Given this list of marker genes AGO4, ATG14, ERCC4, FRMD6, RAD51B, BRWD3, RAB12, SYT6, SBF2, LY75, RACGAP1, PAN3, PEX5L, BTBD3, PSD, NFIA, RTCA, FAT3, AKAP1, RBM25, ACVR1, ACSL1, WDFY3, RAPGEF4, HSPA8, HEG1, LCORL, DAAM1, BRWD1, TAFA1 (TAFA chemokine like family member 1), IGF1, AGO1, ST8SIA5, APCDD1, ZBTB20, ACSL4, NCKAP5, FOSL1, CHD5, FERMT2, BLCAP, CPEB1, PTP4A1, SPATA2, LRRTM2, SPOCK1, DPYSL2, LRP12, MET, TSC1, ZNF862, TFCP2L1, SIX4, USP33, PPARG, PHAF1, ACBD5, CCDC6, GTF2H1, SAR1B, VGLL4, KCNA4, CGGBP1, LGALSL, WDR20, TMOD1, MFSD6, CAPRIN2, SNX2, LPGAT1 (lysophosphatidylglycerol acyltransferase 1), NECTIN3, FBXO48, AAK1, RNF38, G0S2, SPHK2, MIER1, BHLHE41, PIK3CB, ARHGEF4, WDR47, ELK3, NPNT, BPTF, USP28, BTF3L4, MIGA2, MMGT1, OTUD3, LRIG1, JMY, TEX2, BTBD7, BMPR2, THOP1, ITGB8, SLC6A6, ZFYVE9 (NCBI Gene Id 9372), BTAF1, POU4F1, ABHD3, ULK2, ING2, HOXD1, DCBLD2, EPC2, VCF1, HECA, CEP170, RALGPS2, MBNL3, PIK3C2A, DIAPH3, POP7, EGLN3, SERBP1, LSMEM1, TLCD3A, SOX4, MECP2, ABRAXAS2, FBXO28, HIVEP2, LRRK2, PLAA, ZBTB18, RASD1, OSBPL6, G3BP2, TNRC6C, CD69, MYBL1, LONRF3, TBL1XR1, FIBIN, ITPRIPL2, INO80, UBA3, MIGA1, ZNF800, DENND10, TMEM50B, SEL1L3, LMLN, TOGARAM1, MID1IP1, PGM2L1, CCNY, SAMD8, FUT9, GJA1, MTMR10, AR, WEE1, SLC44A1, SPTY2D1, IRF1, PSAP, PHF12, BAHD1, DLL1, WNK1, KRTAP26-1, NHLH2 (nescient helix-loop-helix 2), AGFG1, MDFIC, CYP2U1, CIT, NACC2, CUL3, MAP3K20, HOXA3, PRKD3, THSD7A, JARID2, SULF1, GAREM1, WDR33, PIGA, DNAJC16, AKIRIN2, ABCB7 (NCBI Gene Id 8252), ACBD3, VPS13D, TRPC3, PIKFYVE, ROBO2, EREG, ITPR1, MSMO1, TMEM250, ANKIB1, PCNX1, BTG1, NSD3, HPRT1, HS3ST5, MPHOSPH9, ZBTB4, UBE3B, ARHGAP21, ZNF107, TANC2, SLAIN1, CSMD1, ABCC5, ARHGEF26, EPS15, SHANK2, PMEPA1, FASTK, RRAGD, DICER1 (NCBI Gene Id 4333), TET3, CENPO, BAG5, SYBU, GADD45A, NFIB, ASXL2, SMOC1, DENND4C, SZRD1, RTN1, STIM2, CRACD, ERBIN, CASD1, SNIP1, ARHGAP1, TENT2 (NCBI Gene Id 167153), ZNF217, AKAP11, LDLR, ATG16L1, RFX7, MAF, MACIR, DLG5, JADE1, FOXF2, FYN, CNOT6, SLMAP, KDM2A, CAMSAP2, PIP4P2, ATP6V1B2, MB21D2, CLCN5, UBE2D2, TRIM2, PRUNE2, UBB, CNOT4, CPEB3, PHACTR2, STON2, SCUBE3, TES, CFL2, RUNX3, DCUN1D3, FMR1, CBX6, ARAP2, DOCK3, RAI2, CHST1, CDK19, EMX2 (empty spiracles homeobox 2), PRKAA1, NPAT, PHF20, MAP3K12, PPP6R2, SERINC3, DNAL1, LDAF1, RBBP8, ZNF594, MTCL1, CYSLTR1, KMT2C, CBLB, ZNF609, DSEL, ARL6IP1, RNF145, DGKE, IL1RAP, RPS6KA5, CBFB, RNF216, LRP8, PTPRG, ZMAT3, ARHGAP12, FZD6, MEMO1 (NCBI Gene Id 63983), BMP3, PLCB1, DYNLL2, MDM4, HCFC2, RO60, SLC2A4RG (SLC2A4 regulator), STX6, ESR1, PHF14, SOCS5, MBD2, NRBF2, IMPDH1, RAB30, PDZD11, ERP44, CDS1, KIAA1191, UBXN2B, C2orf15, RAB5A, CLIP1, SH3D19, SALL3, CCDC126, DCAF8, SPEN, PTPN4, KBTBD8, TSHZ1, EDN1, DDX6, SRSF2, SNX31, VPS37A, PPP1R15B, EBF3, ST18, FRZB, PPFIA2, ZEB2, CLTC, USP8, RAP2C, NEUROG1, NABP1, EIF4E2, PAK6, LRP2, DLC1, SNX5, CLCN3, SBNO1, FSD1L, SAMTOR, IL15, EOGT, CBY1, PDIK1L, CD2AP, DYNC1LI2, YTHDF2, TGFBR1, SECISBP2L, SOS2, CNOT7, FMC1, PURG (NCBI Gene Id 29942), R3HDM1, APPL1, POU3F2, ADCY1, ATP12A, TGFBR2, USP13, ENPP5, FSTL5, SKIDA1, MLLT6, NALF1, LRP6, ADAM12, KIF13A, SMARCD2, ZFYVE26, MBNL1, CALM2, SPART, NPEPL1, LDLRAD4, KLF7, SFMBT1, UBE2W, MAPK1, HECW2, INSIG1, DSG1, here is a description of the gene set: Genes predicted to be targets of miRBase v22 microRNA hsa-miR-3666 in miRDB v6.0 with MirTarget v4 prediction scores > 80 (high confidence targets). species: Homo sapiens Human Gene Set: MIR3666 from publication Chen Y, Wang X (PMID 31504780)